The following is a description of a gene set: species: Homo sapiens The neural plate is a thickened layer of cells on the dorsal surface of the gastrula rostral to the node and primitive streak. As development proceeds, the neural plate folds to form a tube that will generate the brain and spinal cord. Failure to completely form a neural tube causes neural tube defects, such as spina bifida, which are the most common birth anomaly of the central nervous system. Though a single structure, the neural plate actually contains two regions formed from different progenitors and regulated by distinct gene expression programs: the anterior neural plate (ANP) gives rise to the forebrain and midbrain and the posterior neural plate (PNP) gives rise to the hindbrain and anterior part of the spinal cord.<br>The ANP arises directly from the epiblast, requires inhibition of BMP signaling by secreted inhibitors from the anterior visceral endoderm (reviwed in Andoniadou and Martinez-Barbera 2013), and expresses SOX2 driven by OTX2, ZIC2, and POU5F1/POU3F1 bound to the N2 enhancer upstream of the SOX2 gene (inferred from mouse homologs in Iwafuchi-Doi et al. 2012). The posterior part of the PNP arises from neuromesodermal cells that express SOX2 driven by WNT and FGF acting through the N1 enhancer downstream of the SOX2 gene (inferred from mouse homologs in Takemoto et al. 2006).<br>Both the ANP and PNP express ZEB2 and SOX1, however the ANP is characterized by high OTX2 expression, while the anterior PNP expresses higher levels of GBX2 (inferred from mouse homologs in Simeone et al. 1992). The boundary between the ANP and the PNP is partly determined by a mutual antagonism between OTX2 and GBX2. OTX2 from the ANP represses expression of GBX2 and GBX2 from the PNP represses expression of OTX2 (inferred from mouse homologs in Wassarman et al. 1997, Martinez‑Barbera et al. 2001, Li et al. 2001). Reactome Pathway: Formation of the anterior neural plate part of: Gastrulation, and this is the list of marker genes: POU5F1, ZEB2, ZNF521, POU3F1, ZIC2, PAX6, OTX2, GBX2, SOX2, NANOG, SOX1